The following is a description of a gene set: studied in species Homo sapiens PCP/CE pathway Human Gene Set: REACTOME_PCP_CE_PATHWAY, and this is the list of marker genes: PSMD1 (NCBI Gene Id 5707), SEM1, DVL2, PSMB7, DVL1, FZD7, PRICKLE1, PSMA2, CLTC, PSMA5, PSMD6, AP2B1, PRKCA, FZD1, PSMC5, PSMD2, SMURF1, RAC2, RHOA, PARD6A, ROR2, RAC1, FZD2, VANGL2, PSMB1, ADRM1, PSMB4, ARRB2, UBC, PSMB5, WNT1, AP2M1, DAAM1, WNT5A, PSMD12, FZD5, DVL3, PFN1, PSMC1, PSMA4, UBA52, SCRIB, PSMD7, FZD6, PRKCG, PSMC2, CLTA, WNT5B (NCBI Gene Id 84728), FZD4, WNT4, CLTB, PSMA3, PSMD11, PSMD14, PSMA1, RAC3, PSMC6, PSMD3, ROR1, SMURF2, PSMA6, PSMB6, RPS27A, PSMC4, WNT11, AP2A2, PRKCB, FZD3, FZD8, PSMB3, AP2S1, AP2A1, PSMB2, PSMD13, UBB, RYK, PSMD8, PSMC3, PSMA7